Given this list of marker genes BMPR1B-DT, ADGRA1, NT5DC2 (NCBI Gene Id 64943), CFAP61-AS1, CYB561, ARC, C1orf226, TMEM130, SCG2, HACD3, MRAP2, PPP1R17, MICU2, ZDBF2, NPAS4, GCH1, UNC5C-AS1, CARTPT, NSMCE3, PNMT, CHGA, RPSAP57, TH, QDPR, NT5C1A, GALR1, LINC02513, SERTM2, HTATSF1, LINC02994, KSR2, TSPYL2, GOT1L1 (glutamic-oxaloacetic transaminase 1 like 1), RLIG1, SLC18A1, NLRP1, PRLHR, FGF14-AS1 (NCBI Gene Id 100874081), CCDC172, FGF14-IT1, UNC80, SMIM45, VWDE, FKBP5, DBH, LINC01982, KLK4, VPS33A, TMIE (transmembrane inner ear), IL13RA2, PENK, CHGB, SIDT1, C1QL1, PRCD, ZNF483, LINC00632, here is a description of the gene set: Marker genes curated from the annotated cluster as represented in the Descartes Human Gene Expression During Development database. species: Homo sapiens from publication Cao J, O'Day DR, Pliner HA, Kingsley PD, Deng M, Daza RM, Zager MA, Aldinger KA, Blecher-Gonen R, Zhang F, Spielmann M, Palis J, Doherty D, Steemers FJ, Glass IA, Trapnell C, Shendure J (PMID 33184181) The gene expression program underlying the specification of human cell types is of fundamental interest. The study authors generated human cell atlases of gene expression and chromatin accessibility in fetal tissues. For gene expression, the study authors applied three-level combinatorial indexing to >110 samples representing 15 organs, ultimately profiling ~4 million single cells. The study authors leveraged the literature and other atlases to identify and annotate hundreds of cell types and subtypes, both within and across tissues. Our analyses focused on organ-specific specializations of broadly distributed cell types (such as blood, endothelial, and epithelial), sites of fetal erythropoiesis (which notably included the adrenal gland), and integration with mouse developmental atlases (such as conserved specification of blood cells). These data represent a rich resource for the exploration of in vivo human gene expression in diverse tissues and cell types. Human Gene Set: DESCARTES_MAIN_FETAL_SYMPATHOBLASTS